The following is a description of a gene set: The chemical reactions and pathways involving any ribonucleoside, a nucleoside in which purine base is linked to a ribose (beta-D-ribofuranose) molecule. Human Gene Set: GOBP_PURINE_RIBONUCLEOSIDE_METABOLIC_PROCESS studied in species Homo sapiens, and this is the list of marker genes: ADK, PNP, ADA, ENPP4 (NCBI Gene Id 57011), ACP3, GNMT, ICMT, XDH, HPRT1, NT5C1B, ADA2, BLOC1S6, MTAP, DGUOK, APRT, NT5C1A, NT5C2, MAPDA, PGM2, NT5E, PRTFDC1, PTGDR